Given this list of marker genes Mfn1, Kpna1, Phf6, Fnbp1, Dsg1b, Rnf2, Snx18, Ppargc1b, Grik2, Eif5, Cts3, Rnf220, Gp1ba, Rasef, Col6a3, Tnpo1, Ott, Atf2, Pcsk5, Cadm1, Cyp26b1, Rnls, Gm15127, Col11a1, Hivep1, Srsf10, Nog, Macroh2a1, Kif26b, Rhot1 (NCBI Gene Id 80692), Gm10439, Dclre1c, Ap4e1, Muc13, Fbxo21, Trpm7, Zfp160, Mtf2, Fzd4, Phf12, Gucd1, Gm15093, Cadm2, Zfp516, Gm15114, Zfp503, Ermp1, Gabrg2, Rnf103 (NCBI Gene Id 232080), Krit1, Dnmt3a, Vcan, Igsf10, Lhx9, Msl3, Myo9a, Rif1, Itch, Akap6, Epha5, Samd9l, Dgkb, Zfp280d, Ints7, Bicd1, Sar1b, 1700129C05Rik, Dgat2, Trmt2a, Tmem248, Tgif2lx2, Wnk3, Foxa1, Khdrbs1, Yipf4, Atp10a, Dab2, Clgn, Pax9, Mmp19, Fgd4, Gm15107, Rnf138, Eif1, Mab21l1, Lims1, Dmxl1, Ccp110, Zeb2, Taf1, Fnip2, Gm15085, Zyg11b, Pcdh15, Gm15080, Zfhx4, Tax1bp1, Dsc3, Klhl7, Ube2w, Arl13b, Rab14, Zfp711, Pcdh9, Zfp354c, Rnd3, Ero1a, Dhx15 (DEAH-box helicase 15, NCBI Gene Id 13204), Zmpste24 (zinc metallopeptidase, STE24, NCBI Gene Id 230709), Txndc9, Edil3, Stx7, Chrnb1, Dlx5, Plppr4, Rbm47, Cds1, Hnrnpa3, Nfyb, Zbtb43, Atf6, Snx16, Klhl5, Agr2, Nf1, Stam, Gm266, Usp33, Rdh13, Tnfsf10, Peli2 (NCBI Gene Id 93834), Sdad1 (NCBI Gene Id 231452, SDA1 domain containing 1), Dmxl2, Uba2, Tgif2lx1, Scg2, Pdk2 (pyruvate dehydrogenase kinase, isoenzyme 2), Pglyrp2, Ndst3, Lcorl, Phip, Rorb, Pank3, Tpk1 (NCBI Gene Id 29807), Anapc10, Dsg1a, Matr3, Mysm1, Srsf3, Gpr141, Gm15091, Dnal1, Hspa13, Flrt2, Cox11, Gpr155, Kctd8, Etaa1, Sema3a, Ostm1, Zc2hc1c, Gm15097, here is a description of the gene set: species: Mus musculus Genes predicted to be targets of miRBase v22 microRNA mmu_miR_7210_5p in miRDB v6.0 with MirTarget v4 prediction scores > 80 (high confidence targets). Mouse Gene Set: MIR_7210_5P from publication Chen Y, Wang X (PMID 31504780)